The following is a description of a gene set: studied in species Mus musculus Mouse Gene Set: MIR_7018_5P from publication Chen Y, Wang X (PMID 31504780) Genes predicted to be targets of miRBase v22 microRNA mmu_miR_7018_5p in miRDB v6.0 with MirTarget v4 prediction scores > 80 (high confidence targets)., and this is the list of marker genes: St8sia4, Sptb (spectrin beta, erythrocytic), Map3k20, Loxl4, Zdhhc21, Cyfip2, 1110004F10Rik, Rnf14, Cdk17, Khdrbs2, Vcpip1 (NCBI Gene Id 70675), Ptprr, Unc80, Sertad2, Slc39a13, Akirin1, Col8a1, Dyrk2, Kank4 (KN motif and ankyrin repeat domains 4), Trappc10, Mapk9, Tnfrsf22, Pou4f1, Prrt4, Urod, Nr3c1, Ms4a13, Cpm (NCBI Gene Id 70574), Gabrg1, Atg14, Unk, Aldh6a1, Pglyrp4, Jak2, Slc13a4, Inpp5b, Spopl, Sorcs1, Stc1, Rps6kl1, Tnrc6a, Pcbp3, Zfp1008, Sec63